Given this list of marker genes ECHS1, HADHB, HADHA, HADH, ACADL, here is a description of the gene set: studied in species Homo sapiens Human Gene Set: REACTOME_BETA_OXIDATION_OF_LAUROYL_COA_TO_DECANOYL_COA_COA Beta oxidation of lauroyl-CoA to decanoyl-CoA-CoA